Given this list of marker genes Mapk3, Ifngr2, Ifng, Ifngr1, here is a description of the gene set: studied in species Mus musculus part of: Interferon gamma signaling This event has been computationally inferred from an event that has been demonstrated in another species.<p>The inference is based on the homology mapping from PANTHER. Briefly, reactions for which all involved PhysicalEntities (in input, output and catalyst) have a mapped orthologue/paralogue (for complexes at least 75% of components must have a mapping) are inferred to the other species. electronically inferred by orthology from the curated human pathway Reactome Pathway: IFNG signaling activates MAPKs